The following is a description of a gene set: species: Homo sapiens Human Gene Set: GOBP_ACTIN_FILAMENT_BUNDLE_ORGANIZATION A process that results in the assembly, arrangement of constituent parts, or disassembly of an actin filament bundle., and this is the list of marker genes: MICAL1, NEDD9, DMTN, RHPN2P1 (rhophilin Rho GTPase binding protein 2 pseudogene 1), CD47, USH1C, MIR149, ARHGEF18, SORBS1, EPHA1, AIF1, ADD2, BAIAP2L2, MKKS (NCBI Gene Id 8195), ARHGEF10L, PXN, DIAPH3, FLNA, STMN1, WNT4, ZYX, SHROOM1, PDXP, ARHGAP28, PPM1F, FAM107A, BBS4, CCDC88A, BAIAP2, PFN1, FSCN3, CLASP2, MYO1B, CDC42, MET, RHPN2, DPYSL3, PDLIM1, SWAP70, SMAD3 (SMAD family member 3), CX3CL1 (C-X3-C motif chemokine ligand 1), PRKN, MTSS1, BAG4, SRC, MIR138-1, PLS3, SYNPO2L, PLEK, RFLNB, SHANK3, PHACTR1, FSCN2, ZEB2, FSCN1, RAPGEF3, RHOD, ARRB1, RHOC, MIR20A, PAK2, CORO1B, TGFBR1, PTGER4, SHROOM2 (shroom family member 2), APOA1, ESPN, WAS, SDC4, NF2, TACR1, RFLNA, SYNPO (synaptopodin), INPP5K, LPAR1, PAWR, RHOA, LCP1 (NCBI Gene Id 3936), CGNL1, ACTG1, SHANK1, SORBS3, RGCC, TMEFF2, BLOC1S6, TSC1, ITGB5, TPM1, LIMD2, EVL, OAZ3, TESK1, PFN3, ARHGEF5, LUZP1, FHOD1, SFRP1, DLC1, ASAP3, ARAP1, CCN2, LIMCH1, TAC1, SHTN1, CLASP1, PDCD10, CUL3, MYOC, FHDC1, ABL1, PPFIA1, SPIRE1, TGFB3, MARCKS, TJP1, SLC9A1, MYL9, FRMD7, RHPN1, S100A10, ITGB1BP1, DNM2, BAIAP2L1, ARHGEF15, ELN, LIMA1, MTOR, ACTN1, FERMT2, FAM171A1, FMN2, NRP1, F11R, ESPNL, AIF1L, EPS8, TNFAIP1, SRF, TTC8, ARHGAP6, ITGB1, KCTD13, S1PR1, RDX, TACSTD2, ALMS1, ARHGEF10, RAC1, CORO2B, PHLDB2, SYNPO2, AMOT, ROCK1, LIMK1, CALD1, PFN2, PIK3R1, PAK1, MIR21, ADD1, PLS1, CFL1, ROCK2, SERPINF2 (NCBI Gene Id 5345), SPIRE2, BRAF, PIK3R2, GPR65, VIL1, EZR, HSP90B1, PPM1E, CARMIL1, WASF2